Given this list of marker genes Ctps1, Rrm1, Ak5, Cmpk1 (cytidine/uridine monophosphate kinase 1), Nme1, Ak6, Nme2, Ctps2, Ak7, Txn1, Nme3, Rrm2b, Nudt13, Guk1, Ak8, Tyms, Dctd, Txnrd1, here is a description of the gene set: This event has been computationally inferred from an event that has been demonstrated in another species.<p>The inference is based on the homology mapping from PANTHER. Briefly, reactions for which all involved PhysicalEntities (in input, output and catalyst) have a mapped orthologue/paralogue (for complexes at least 75% of components must have a mapping) are inferred to the other species. studied in species Mus musculus part of: Metabolism of nucleotides electronically inferred by orthology from the curated human pathway Reactome Pathway: Interconversion of nucleotide di- and triphosphates